The following is a description of a gene set: from publication Johnson K, Hashimshony T, Sawai CM, Pongubala JM, Skok JA, Aifantis I, Singh H (PMID 18280186) Human Gene Set: GSE10273_HIGH_IL7_VS_HIGH_IL7_AND_IRF4_IN_IRF4_8_NULL_PRE_BCELL_DN Genes down-regulated in IRF4 and IRF8 null pre-B cell treated with 5ng/ml IL7 versus those transduced with IRF4. species: Homo sapiens Productive rearrangement of the immunoglobulin heavy chain locus triggers a major developmental checkpoint that promotes limited clonal expansion of pre-B cells, culminating in cell cycle arrest and rearrangement of the kappa (κ) or lambda (λ) light-chain loci. B lineage cells lacking the related transcription factors IRF-4 and IRF-8 undergo a developmental arrest at the cycling pre-B cell stage and are blocked for light-chain recombination. Using Irf-4,8-/- pre-B cells we demonstrate that two pathways converge to synergistically drive light-chain rearrangement, a process that is not simply activated by cell cycle exit. One pathway is directly dependent on IRF-4, whose expression is elevated by pre-BCR signaling. IRF-4 targets the κ 3′ and λ enhancers to increase locus accessibility and positions a kappa allele away from pericentromeric heterochromatin. The other pathway is triggered by attenuation of IL-7 signaling and results in activation of the κ intronic enhancer via binding of the transcription factor, E2A. Intriguingly, IRF-4 regulates the expression of CXCR4 and promotes the migration of pre-B cells in response to the chemokine CXCL12. We propose that IRF-4 coordinates the two pathways regulating light-chain recombination by positioning pre-B cells away from IL-7 expressing stromal cells. We used microarrys to identify the changes in gene expression under different levels of the cytokine IL-7 and after rescue of genetic defect., and this is the list of marker genes: FCRLA, KLHL32, KRT25 (keratin 25), PRMT5, TDP1, GPS2, CAPSL, ABTB2, SNN, MARCKSL1, TOMM40, FAM228A, CD2AP, KIF11, RASGRP3, DDC, PCK2, ITGA4, NLRC3, ABCF2, FARS2 (NCBI Gene Id 10667), SURF2, INPP5D, EPS8, KIF2C, PYGM, HMMR, MEIS3, TWSG1, RALY, FGF13 (NCBI Gene Id 730528), SRFBP1, FAM72A, CDKN1A, KMT5A, FKBP8, PHC1, LY9, DNLZ, TERT, SMARCA4, HLA-DOB, PRDM8, ARPC4, ALDH7A1, MORN2, SPG11, PLP2, LHFPL6, BLNK, PDE2A, CARHSP1, ZNF354C, OXA1L, MISFA, WDR35, EGR1, PPP1R16B, FCHO1, PRDX4, MYLK, GALK1 (NCBI Gene Id 2584), NUAK1, SH2D6, ENPP6, CSNK1G2, PHKG2, CTCF, PTPRCAP, PSRC1, NDUFA9, LGALS9B, SSTR3, INKA1, RRAGD, PREP, ART4, INTS1, RAPGEF5, FAU, SLC25A1, N4BP3, LGR5, CENPA, BUD23, MYO1E, RAB24, HSPA1B, RMI2, DOHH, FOXO1, SLC1A7, RCN3, XRCC5, SYK, SKA1, CENPL, TENT5C, NDUFS3, CDK1, SERPINB6, TRIB2 (NCBI Gene Id 28951), BMAL1, ZNHIT2, HDAC8, HCLS1, DPH3, SSBP4, DLGAP5, MVK, NOLC1, CD74, TRMT112, CARM1, IL17RA, TSPAN13, TMEM98, NSUN5, REX1BD, CYB561A3, GPAA1, ATP5MC2, MYEF2, RHOT2, PRAF2, TMEM119, AP2S1, NRF1, THOP1, NGEF, SEMA7A, UGT2B4, SCN3B, ZNF512, SRPK3, CDR2 (NCBI Gene Id 1039), IGHM, TMEM121, BANK1, CDKN2C, GFRA1, TACC3, EGFL6, MPRIP, PUF60, NRM, TNFAIP3, REM1, TCF25, FBXO5, IFT56, KLF2 (NCBI Gene Id 51713), CCDC9, DIAPH3, ECSIT, ADGRB1, ZFTA, NCAPG, LONP1, EZR, FXYD1, JUN (NCBI Gene Id 3725), FTH1, MTCH1, NUSAP1, SP2, NCAPD2, CENPE, PAG1, CRACDL, CAV2, GPSM2, HAND1, LRRC8C, UBE2C, GNL1, CYB5D2, ENDOU, SMKR1, EPB41L5, IL18 (NCBI Gene Id 3606), MYO1C, TCF3, SGK1, CD5, CEL, XRN2, PRKCB, BCL11A, SEPTIN6, CHERP, CCDC124, HAUS4, KCNK5, GSN, FAM234B, TXNRD3, ELAC2, TBXA2R, ASPM